The following is a description of a gene set: Mechanisms regulating self-renewal and cell fate decisions in mammalian stem cells are poorly understood. We determined global gene expression profiles for mouse and human hematopoietic stem cells and other stages of the hematopoietic hierarchy. Murine and human hematopoietic stem cells share a number of expressed gene products, which define key conserved regulatory pathways in this developmental system. Moreover, in the mouse, a portion of the genetic program of hematopoietic stem cells is shared with embryonic and neural stem cells. This overlapping set of gene products represents a molecular signature of stem cells. Genes in the expression cluster 'Early Progenitors Shared': up-regulated in hematopoietic progenitors from adult bone marrow and from fetal liver. from publication Ivanova NB, Dimos JT, Schaniel C, Hackney JA, Moore KA, Lemischka IR (PMID 12228721) Human Gene Set: IVANOVA_HEMATOPOIESIS_EARLY_PROGENITOR studied in species Mus musculus, and this is the list of marker genes: PRDX1, DHCR7, DAPP1, TMED10, P3R3URF (PIK3R3 upstream open reading frame), WEE1, NKG7, ADAMTSL1, CTNNBL1, DIS3L, TDRKH, REXO5, SNAPC1, FZD7, RSRC1, SUCLA2, LCLAT1, DPAGT1, PSMB10, EEF2KMT, CD34, ANAPC11, PGM3, OPN3, PSMA8 (NCBI Gene Id 143471), ECHDC3, DICER1, ZNF383, POGLUT2, VIPR2, BRI3BP, UBE2Q2, ATG10, AFG2B (AFG2 AAA ATPase homolog B), CCDC22, PSD4, RMDN2, RPL18, WDR36, AHCY, CENPV, MED14, ABCC4, PAK1, PDZPH1P, PRKRA, DCUN1D4, TMEM201, OGFR, KDM2B (NCBI Gene Id 84678), SPPL2A, CFAP418, EMILIN1, MFSD4A, HEG1, VPS33B, NUMBL, SEPTIN11, LRRC34, RPGR, ZDHHC9, PDXK, ZNF607, PPRC1, POLR1H, LPAR6, ALS2, GTF2I, MMD, KLHDC9, ALDH7A1, GTPBP10, BCKDHA, DGCR2, TMEM248, RPL22, RAPGEF3, MRPS30, PINX1, MAP1A, GSTM4, NXPH4, ARMCX4, C8orf48, LSM11, BBS4, SDR9C7, AKR1B10, UMPS, CHN2, GBP4, VMA21, ABITRAM, ASRGL1, SLC35B2, RBM28, WDR12, GPATCH4, PRR3, POGLUT1, IP6K2, YLPM1, HIF1AN, SLITRK1 (SLIT and NTRK like family member 1), PLEKHA4, PANK1, ICE2 (interactor of little elongation complex ELL subunit 2), PARP8, DIRAS2, RPS20, NOLC1, SPN (NCBI Gene Id 6693), SLC6A20, UBE3A, BZW2, CPSF3, TMEM98, COX15, ZNF830, ADGRG3, LUC7L, SUPV3L1, PPAN, ELOVL5 (NCBI Gene Id 60481), SPAST, NRROS, DBIL5P, UBE2Q1, QDPR, TIGAR, TMEM218, NME2, POLI, MCMBP, SMIM30, PPIF, SOCS6, PRPSAP1, TTF2, PDIA5, SLC10A7, BCOR (NCBI Gene Id 57686), ARCN1, CD69, TRAK1, SYCE2 (synaptonemal complex central element protein 2), PITPNC1, SNHG7, SLC38A10, VPS11, MARS2, VARS2, ARSB, FDX1, S100A1, CLASP1, UFM1, G6PC3, SUV39H2, CRTAC1, NCL, H2AZ2, SRP68, LRRC59, PRPF4, MCEE, RABGGTA, RASL10A, C15orf39, FAM90A2P, CENPM, NRBF2, CSRP1, CCDC86, TCHHL1, UQCC4, UTP6, FGF3, PTGER3, C6orf226, GRIA3, UBASH3A, SRD5A1, DDX31, ILF3, CRELD2, CLUH, CUL2, MACROH2A1, ZZZ3, TEN1, TRABD2B, MTMR4, GORASP2, NUP42, ABHD11, BFSP2, MIS18BP1, ELP3, BCL2, CAND1, RETSAT (retinol saturase), OBI1, RPS6KA5, ZRANB3, SMUG1, CTDSPL2, ARHGAP6, SLC25A53, TRMT2B, PPP1R14B, GEMIN4, MLEC, SHISA2, STRN4, CHD5, RCC2, COMMD7, HSF2BP (NCBI Gene Id 11077), KCTD18, SAE1, CBFB, MANBA, ANKLE2, PPA1 (NCBI Gene Id 5464), SLC4A8, STYX, DYNLRB1, L3MBTL3, AARS1, PRPF40A, PRKDC, TMEM250, ESD, SPR, GNPTAB, PREP, CST7, PLD6, KIF21A, GMDS, SLF1, LXN, TMED4, GALK2, RIPK1, LCORL, CDCA7L, CRYZL1, MACROD1, PEX7, MGAT2, MANF, GGCT, ZNF213, RBM34, OGFOD3, VAPB, HSPA1A, ING5, NAA60, CMTR2, PTF1A, IDH2, TAF15, SHISA7, ELP6, DLAT, PARD3B, DPH5, PPP1R11, GLB1, COMMD1, ATPAF1, DBT, C14orf93, TTLL4, ACSM2B, C1orf131 (NCBI Gene Id 128061), SLC35A1, RBM19, PATZ1, PALS2, PFAS, SUGCT, SMIM36, SOSTDC1, LMF1, PAOX, DDX59, GID4, CDK4, NLN, PPFIBP1, MYB, STAM, NPEPL1, PACC1, IFTAP, DEPTOR, PPM1F, PPID, XKR8, RAMP3, ABRACL, MGAT5, LRP12, RFX7, METTL16, RNF157, MIR221, TUBGCP5, DDX28, FPGS, DMAC2, TXNDC12, ZWINT, ZNF787, ZNF708, GNB4, GNA15, LYPLAL1, ZNF536, RNASEH1, SLCO3A1, DCP2, MRPS27, SDAD1, EXOG, MTMR7, DHX9, UQCC3, PDAP1, DDX51, SFXN2, BCKDHB, TFB2M, SNX9, SMN2, ODF2L, SEC61A1, B3GALT6, HDHD2, HROB, UQCC1, HIBADH, CYB5B, NUP62, FOXK1, SLC22A17, TTLL9, TRIM13, GART, SINHCAF, MRPL45, P2RY14, CDK6, PRTN3, TAGLN2, NAXD, GTF2A1L, TMEM161A, MDH1, B4GALT4, MRPS12, SEC23IP, PPP1R13B, IRX2 (NCBI Gene Id 93965), MRPS26, SPRED2, GMPS, DIMT1 (DIM1 rRNA methyltransferase and ribosome maturation factor), PHF14 (PHD finger protein 14), GOPC, URM1, MCM3, ANKRD45, GSTO1, EXTL2, GATB, DNAJC15, G3BP1, SNAPC5, LDLRAD3, ZMYM3 (zinc finger MYM-type containing 3), SLC25A15, DCTD, CILK1, HPN, ABHD17C, BBOF1, ZNRF2, ABL2, ANKRD23, TESPA1, CUX1, C9orf85 (NCBI Gene Id 138241), FMC1, SLC22A3, TOX, RNMT, PRMT6, CMTM7, OXCT1, FUT7, SEPTIN6, KCNK12, ALKBH1, GCSH, FASTKD1, BEX4, SH2D5, MRPL44, FYTTD1, SF3A2, HSPA9, KYAT3, TDRD3, MTRF1, WDFY4, KLHL5, SNRPB2, SHMT1, HERC6, RIPK3, PARP1, PDP2, IMPA2, PAQR7, GNPNAT1, DTNBP1, CHML, RIOX2, FBXO45, DDX18, PFDN4, SIRT3, LBP, CCDC8, SNAPC2, LYSMD4, AK4, RNF130, ARL2, RRP7A, IL36B